Given this list of marker genes Ireb2, Hfe, Bmp6, Tfr2, Slc25a39, Trf, Tfrc, Gpld1, B2m, Tfap2a, here is a description of the gene set: studied in species Mus musculus Mouse Gene Set: GOBP_CELLULAR_RESPONSE_TO_IRON_ION Any process that results in a change in state or activity of a cell (in terms of movement, secretion, enzyme production, gene expression, etc.) as a result of an iron ion stimulus.